Given this list of marker genes BPNT2, ABHD14B, SULT2A1, BPNT1, SULT1E1, SULT1A3, SULT2B1, SULT1A2, SULT6B1 (NCBI Gene Id 391365), SULT1A4, SULT1A1, TPST1, SULT1C2 (NCBI Gene Id 6819), PODXL2, TPST2, SULT1B1, SULT1C4, SULT4A1, here is a description of the gene set: species: Homo sapiens Two groups of sulfotransferease (SULT) enzymes catalyze the transfer of a sulfate group from 3-phosphoadenosine 5-phosphosulfate (PAPS) to a hydroxyl group on an acceptor molecule, yielding a sulfonated acceptor and 3-phosphoadenosine 5-phosphate (PAP). One is localized to the Golgi apparatus and mediates the sulfonation of proteoglycans. The second, annotated here, is cytosolic and mediates the sulfonation of a diverse array of small molecules, increasing their solubilities in water and modifying their physiological functions. There are probably thirteen or more human cytosolic SULT enzymes; eleven of these have been purified and characterized enzymatically, and are annotated here. These enzymes appear to be active as dimers. Their substrate specificities are typically broad, and not related in an obvious way to their structures; indeed, apparently orthologous human and rodent SULT enzymes can have different substrate specificities, and none has been exhaustively characterized. The substrates listed in the table and annotated here are a sample of the known ones, chosen to indicate the range of activity of these enzymes and to capture some of their known physiologically important targets. Absence of a small molecule - enzyme pair from the table, however, may only mean that it has not yet been studied. part of: Phase II - Conjugation of compounds Reactome Pathway: Cytosolic sulfonation of small molecules